The following is a description of a gene set: Mouse Gene Set: GOBP_REGULATION_OF_CHROMOSOME_SEGREGATION species: Mus musculus Any process that modulates the frequency, rate or extent of chromosome segregation, the process in which genetic material, in the form of chromosomes, is organized and then physically separated and apportioned to two or more sets., and this is the list of marker genes: Smarca2, Becn1, Ttk, Bub3, Ccnb1-ps, Actl6b, Nuf2, Cit, Iho1, Ncaph2, Tpr, Birc5, Actb, Riok2, Spc24, Lcmt1, Hecw2, Rb1, Anapc2, Ik, Spdl1, Ube2c, Cep192, Smarca4, Pcid2, Csnk2a2, Smc2, Phf10, Usp44, Aurkb, Prap1, Smarcb1, Smc4, Fbxo5, BC005624, Plscr1, Cdk5rap2, Kat2b, Ppp2r2d, Dpf2, Anapc11, Numa1 (nuclear mitotic apparatus protein 1), Anapc1, Ppp2r2a, Rad21, Klhl22, Kif2c, Mad1l1, Chfr, Rmi2, Dpf3, Tex14, Smarcd2, Cul3, Anapc7, Ncapd2, Cenpe, Cdc27, Bub1b, Plk1, Mad2l1bp, Zwilch, Mapk15, Smarcc2, Mki67, Nsmce2, Hnrnpu, Ncapg2, Bub1, Chtf18, Cdc6, Smarcd3, Smc6, Pum1, Cdc23, Zfp207, Zwint, Ndc80, Cdk1 (cyclin dependent kinase 1), Arid1a, Smc5, Pbrm1, Bcl7b, Arid2, Rcc2, Ncaph, Incenp, Bcl7c, Cdc16, Mad2l1, Hormad1, Bcl7a, Pum2, Ska1, Anapc4, Psmg2, Sirt1, Kat5, Ccnb1, Csnk2a1, Mos, Cdca8, Anapc15, Rad18, Kntc1, Arhgap33os, Anapc5, Spc25, Dync1li1, Gen1, Tacc3, Sirt2, Anapc15-ps, Haspin, Ncapd3, Nek6, Apc, Ube2u, Prpf4b, Smarcc1, Kif2b, Actl6a, Xrcc3, Trip13, Smarcd1, Dpf1, Cdc20, Ska3, Knl1, Brd7, Zw10, Atm, Smarce1, Khdc3, Dusp1